Given this list of marker genes BEST1, NRCAM, IRAG2, KDR, PDGFRA, IL6, IL6ST, MYC, MYB, SERPINB2 (NCBI Gene Id 5055), CXCL5 (NCBI Gene Id 6374), IL7R, ITGA1 (NCBI Gene Id 3672), COL7A1, MAP3K13, PCP4, RHOB, MAP2, IL2RB, PIM2, RAB11B, RB1, THBS1, CXCL3, AKR7A3 (aldo-keto reductase family 7 member A3), NEDD9, RIPK1, EDN1, MAFK, MERTK, PTP4A3, CHST7, AR, TNP2, CCL8, APOD, SSTR2, B4GALT1, SLC16A1, SPTBN1, PPARA, KRT32, STAT1, SDC1, MMP12, EFS, TNFAIP2, STAT4, CCL5, CDX2, SOD2, SERPINB4, OASL, ACKR3, FSTL3, SECTM1, CSF2, LTC4S, BAK1, KCNA1, IL1B, FLT1, AKAP8L, ISG20, CXCL2, NFRKB, PTPRZ1, DUSP1, ACVR1B, LMOD1, CCNT1, HBEGF, TFPI2, CCL20, GFRA2, IL15RA, TRIM25, here is a description of the gene set: Human Gene Set: MAHAJAN_RESPONSE_TO_IL1A_UP species: Homo sapiens Genes up-regulated in corneal fibroblasts after treatment with IL1A. PURPOSE: To identify changes in gene expression in human corneal fibroblasts after exposure to interleukin-1alpha. METHODS: RNA was isolated from cultured human corneal fibroblasts after treatment with interleukin-1alpha and subjected to DNA microarray analysis. Changes in gene expression were determined by comparison with untreated cells in three independent experiments after a Bayesian statistical analysis of variance. RESULTS: Changes in gene expression were reproducibly observed in genes representing previously identified and novel chemokines, matrix molecules, membrane receptors, angiogenic mediators, and transcription factors that correlated with pathophysiological responses to inflammation. Dramatic increases in gene expression were observed with exodus-1 (CCL20), MMP-12, and RhoA. CONCLUSIONS: DNA microarray analysis of the corneal fibroblast response to interleukin-1alpha provides important insight into modeling changes in gene expression and suggests novel therapeutic targets for the control of corneal inflammation. from publication Mahajan VB, Wei C, McDonnell PJ 3rd (PMID 12091409)